Given this list of marker genes Asl, Arg1, Ass1, Nmral1 (NCBI Gene Id 67824), Otc, Cps1, Arg2, Slc25a15, Nags, Slc25a2, here is a description of the gene set: species: Mus musculus Urea cycle Mouse Gene Set: REACTOME_UREA_CYCLE